Given this list of marker genes Pbx1, Lztfl1, Gas2, Ppp1r21, Itpka, Slc39a9, Cd209e, Fam78b, Ubp1, Orc3, Mecp2, Hps3, Ap2b1, Cln5, Magohb, Fut9, Mindy2, Dkk1, Zfp750, Tmem161b, Ndufa6, Egr2, Slc30a4, Kcnb1, Sdf2l1, Sp8, Nol8, Hlf, Tac1, Egln3, Brk1, Gatad1, Prss41, Wtap, Calb1, Pcdh7, Tmem200a, Syt11, Fyb2, Scrn3, Rab39, Ids, Fignl1, Rarb, Postn, Gabrg1, 2900026A02Rik, Trim30d, Dnaja2, Nfkbiz, Ube2k, B3galt2, Pakap, Slc24a5, Nfkbid, Csrnp3, Fgf14, Myo6, Selenos, Fam174a, Tcp10b, Zdhhc6, Gja1, Arpp21, Ppm1e, Hivep1, Trim11, Zfp40, Shisa6, Mycbp, Vcan, Uba2, Dgkb, Cfap70, Capn12, Tmem181a, Nob1, Zfp46, Fndc3a, Clasp2, Pmp22, Ppp4r2, Agpat3, Nkain2, Atp2c1, Ints12, Fyco1, Syn2, Dlgap4, Neil3, Fam241a, Hnrnpr (heterogeneous nuclear ribonucleoprotein R), Eaf1, Tacc3, Cep68, Krt20, Ntrk3, Rspo2, Or7d10, D630039A03Rik, Kcnip4, Drosha, Il7, Dio2, Zfpm2, Cdh8, Il13ra2, Grik4, A4gnt, Smad9, Sfmbt1, Trim30b, Pate3, here is a description of the gene set: Genes predicted to be targets of miRBase v22 microRNA mmu_miR_6537_5p in miRDB v6.0 with MirTarget v4 prediction scores > 80 (high confidence targets). Mouse Gene Set: MIR_6537_5P from publication Chen Y, Wang X (PMID 31504780) studied in species Mus musculus